Given this list of marker genes IRX2, TUFM, EXD2, PCDH12 (protocadherin 12), PRPF18, HSD3B7, FURIN, IRX2-DT, IL2RG, SNCAIP, SSBP3, SCARF1, SMUG1, NSD2, PPFIA2, SPP2, GRHL3, CPEB4, SIRT6, ESRRG, ATP13A2 (ATPase cation transporting 13A2), MTF1, DCDC1, DNAJB1, ARID4A, DNAJC13, APBA1, TAOK1, DNAJC24, LRRTM1, NR1D1, CCDC25, PPME1, RPL41, DALRD3, CAPZA1, IPO4, NDUFAF3, ADCY2, TOPBP1, ZC3H10, DDIAS, YRDC, C1orf122, ST7L, JAG1, MYH10, PRCP, AP1B1, SOX10, MYO18A, LINC01565, here is a description of the gene set: Human Gene Set: YTTCCNNNGGAMR_UNKNOWN from publication Xie X, Lu J, Kulbokas EJ, Golub TR, Mootha V, Lindblad-Toh K, Lander ES, Kellis M (PMID 15735639) Comprehensive identification of all functional elements encoded in the human genome is a fundamental need in biomedical research. Here, we present a comparative analysis of the human, mouse, rat and dog genomes to create a systematic catalogue of common regulatory motifs in promoters and 3' untranslated regions (3' UTRs). The promoter analysis yields 174 candidate motifs, including most previously known transcription-factor binding sites and 105 new motifs. The 3'-UTR analysis yields 106 motifs likely to be involved in post-transcriptional regulation. Nearly one-half are associated with microRNAs (miRNAs), leading to the discovery of many new miRNA genes and their likely target genes. Our results suggest that previous estimates of the number of human miRNA genes were low, and that miRNAs regulate at least 20% of human genes. The overall results provide a systematic view of gene regulation in the human, which will be refined as additional mammalian genomes become available. studied in species Homo sapiens Genes having at least one occurrence of the highly conserved motif M150 YTTCCNNNGGAMR in the regions spanning 4 kb centered on their transcription starting sites. The motif does not match any known transcription factor binding site.